The following is a description of a gene set: Any process that modulates the chemical reactions and pathways involving any of a class of organic compounds that contain the carbonyl group, CO, and in which the carbonyl group is bonded only to carbon atoms. The general formula for a ketone is RCOR, where R and R are alkyl or aryl groups. Human Gene Set: GOBP_REGULATION_OF_KETONE_METABOLIC_PROCESS species: Homo sapiens, and this is the list of marker genes: MIR33A, BMP6, GGCX, PRKG1, GPIHBP1, PDK4 (NCBI Gene Id 5166), MIR185, STAR, ADM, PDK2, SREBF1, STARD4, PROX1, MIR132, MLXIPL, IRS1, FABP3, UBR4, BRCA1, MFSD2A, MIR766, ACADL, SLC45A3, CLCN2, TWIST1, ACADVL, CREB1, DGKQ, FMO2, BMP5, BCKDK, APOC2, MLYCD, WNT4, APPL2, PTGS2, MTLN, ACACB, ERLIN1, AVP, PDK1, FMO1 (flavin containing dimethylaniline monoxygenase 1), PLIN5, FGFR4, FMO4, CD74, ERFE, SOX9, SIRT1, NR1H2, UGT1A6, SLC22A13 (solute carrier family 22 member 13), GIP, INS, GHSR (growth hormone secretagogue receptor), AKT2, BGLAP, INSIG2, DGAT2, MALRD1, DAB2, APOC3, EGR1, TPK1, SCAP, TYSND1, PPTC7, GDF15, UGT1A10, TREX1, UGT1A3, SIRT5, ERLIN2 (ER lipid raft associated 2), ABCD1, LPGAT1, UGT1A1, TRIB3, APOC1, MIR204, SNCA, EIF6, SIRT2, DKK3, PPARD, BMP2, ABCB11, AKT1 (AKT serine/threonine kinase 1), SIRT4, CPT1A, MIR342, CYP7A1, MIR548P, PPARA, NCOR2, MIR30C1, ABCD2, LONP2, UGT1A7, NCOR1, CEACAM1, NR1H4, NR1H3, PDK3, H6PD, ADCK2, AVPR1A, MIR182, PANK2, APOA4, WDTC1, PLAA (NCBI Gene Id 9373), MID1IP1, PPARGC1A, DKKL1, ELOVL5, FABP5, INSIG1, ADIPOQ, APOA5, PLA2G3, CES1, IL1B, GPRC6A, KLHL25, RDH10, UGT1A8, AKR1C3, MIR96 (microRNA 96), DCAF5, PGK1, IRS2, PRMT3, NFE2L1, ANGPTL4, FGF19, PIBF1, KAT2B, PRKAG2, UGT1A4, REST, CAV1, ETFBKMT, UGT1A9, NR1D1, PPARG